Given this list of marker genes IGLV2-11, TRPC1, IGHV4-59, CD79A, IGLV3-21 (NCBI Gene Id 28796), AHCYL1, IGKV3D-20, IGKV1D-16, IGHV3-11, IGKV1D-12, IGKV1-16, IGLV2-23, NCK1, IGKV1D-39, IGKV4-1 (NCBI Gene Id 28908), CD19, IGLV1-51, IGHD (immunoglobulin heavy constant delta), IGLV2-8, IGHV1-2, IGKV1-5, IGKV1-33, IGLV3-1, IGHV3-30, ORAI1, IGLV3-27, IGLV1-47, IGLV3-25, IGLC7, CD22, IGKV3-11, IGLV2-14, IGHV3-23, BTK, BLK, IGKV2-28, FYN, IGHV1-46, IGLV, DAPP1, GRB2, IGKC, PLCG2, IGKV3-20, IGHV3-7, SH3KBP1, SOS1, ORAI2, IGKV1-12, PIK3R1, IGLV6-57, IGHV3-53, IGLV1-40 (immunoglobulin lambda variable 1-40, NCBI Gene Id 28825), IGHV3-13, PIK3CD, LYN, IGLV1-44, STIM1, IGLC1, IGHV4-34 (NCBI Gene Id 28395), IGLC3, ITPR3, CALM1, SYK, ITPR2, IGLC2, IGLV7-43, IGKV2D-40, PIK3AP1, IGHV1-69, IGLC6, IGLV3-19, IGKV5-2, IGKV2-29, IGHV, IGKV2-30, IGHV3-9, IGKV1D-33, VAV1, IGHV3-33, IGHV2-5, PTPN6, BLNK, IGHV3-48, IGHV7-81 (NCBI Gene Id 28378), IGHV4-39, IGHM, IGKV3-15, IGHV2-70, CD79B, IGKV2D-28, IGKV2D-30, IGKV1-17, ITPR1, IGKV1-39, here is a description of the gene set: part of: Signaling by the B Cell Receptor (BCR) Reactome Pathway: Antigen activates B Cell Receptor (BCR) leading to generation of second messengers Mature B cells express IgM and IgD immunoglobulins which are complexed with Ig-alpha (CD79A, MB-1) and Ig-beta (CD79B, B29) to form the B cell receptor (BCR). Binding of antigen to the immunoglobulin activates phosphorylation of immunoreceptor tyrosine-based activation motifs (ITAMs) in the cytoplasmic tails of Ig-alpha and Ig-beta by Src family tyrosine kinases, including LYN, FYN, and BLK. The protein kinase SYK may also be involved in phosphorylating the ITAMs.<br>The protein kinase SYK binds the phosphorylated immunoreceptor tyrosine-activated motifs (ITAMs) on the cytoplasmic tails of Ig-alpha (CD79A, MB-1) and Ig-beta (CD79B, B29). The binding causes the activation and autophosphorylation of SYK.<br>Activated SYK and other kinases phosphorylate BLNK (SLP-65, BASH) and BCAP. LYN and FYN phosphorylate CD19. Phosphorylated BLNK, BCAP, and CD19 serve as scaffolds which recruit effectors to the plasma membrane and assemble large complexes, the signalosomes. BCAP and CD19 recruit phosphoinositol 3-kinase (PI3K). BLNK recruits phospholipase C gamma (predominantly PLC-gamma2 in B cells, Coggeshall et al. 1992), NCK, BAM32, BTK, VAV1, and SHC. The effectors are phosphorylated by SYK and other kinases.<br>Phosphorylated BCAP recruits PI3K, which is phosphorylated by a SYK-dependent mechanism and produces phosphatidylinositol-3,4,5-trisphosphate (PIP3). Phosphorylated CD19 likewise recruits PIP3K. PIP3 recruits BAM32 and BTK (de Weers et al. 1994, Baba et al. 2001) to the plasma membrane via their PH domains. PIP3 also recruits and activates PLC-gamma1 and PLC-gamma2. BTK binds phosphorylated BLNK via its SH2 domain. BTK phosphorylates PLC-gamma2, which activates phospholipase activity. Phosphorylated BLNK recruits PLC-gamma, VAV, GRB2, and NCK.<br>PLC-gamma hydrolyzes phosphatidylinositol-4,5-bisphosphate to yield inositol-1,4,5-trisphosphate (IP3) and diacylglycerol. IP3 binds receptors on the endoplasmic reticulum and causes release of Ca2+ ions from the ER into the cytosol. The depletion of calcium from the ER in turn activates STIM1 to interact with ORAI and TRPC1 channels (and possibly other TRP channels) in the plasma membrane, resulting in an influx of extracellular calcium ions. studied in species Homo sapiens